The following is a description of a gene set: Intracellular signaling by second messengers species: Homo sapiens Human Gene Set: REACTOME_INTRACELLULAR_SIGNALING_BY_SECOND_MESSENGERS, and this is the list of marker genes: PRKACB (NCBI Gene Id 5567), PDE1B, PIK3R1, PTEN, PPP2R5C, FGF17, PHLPP1, ADCY7, EGF, MAPK1, RRAGD (NCBI Gene Id 58528), CHD4, PRKAR1A, PRKCD, PSMD6, CD28, JUN, FGF1, FGF2, TRAF6, HDAC5, EED, GRK2, NTF4, FGF5, RPS6KB2, FOXO4 (NCBI Gene Id 4303), PSMB1, MAPKAP1, PIK3AP1 (NCBI Gene Id 118788), HDAC7, TSC2, PLCG1, ATN1, CREB1, CAMK4, CBX8, HDAC1 (histone deacetylase 1), PSMD13, KLB, PRKAR2B, CBX6, PHC3, LAMTOR2 (late endosomal/lysosomal adaptor, MAPK and MTOR activator 2), PHC1, NEDD4, PDGFRB, PDGFA, PIP4K2A (NCBI Gene Id 5305), PDE1C, RRAGA, PRKAR1B, RICTOR, CDKN1B, PSMC2, ADCY1, UBB, PTPN11, PSMA5, KITLG (KIT ligand), UBC, LAMTOR1, EREG, PSMB6, LCK, CD19, UBA52, PDE1A, PPP2R5E, ICOS, VAV1 (NCBI Gene Id 7409), GAB2, ADCY9, PSMA7, HDAC2, PRKACG, PSMA1, FGF16, CSNK2A2, ADCY3, FGF3, CSNK2A1, PPP2CB, RHOG, PPP2CA, ERBB3, PIK3CG, RRAGC, GSK3A, IRS2, MDM2, AKT3, KIT (NCBI Gene Id 5086), MTA3, FGF10, GRB2, PIP4K2B, EGR1, SLC38A9, PML, FGF8, KPNA2, CDKN1A, FGF7, FOXO1, GATAD2A, SNAI1, IRS1, AKT2, ITPR3, MECOM, RRAGB, CAMK2B, EPGN, PSMA4, INS, FLT3LG, BTC, FGF19, CD86 (NCBI Gene Id 942), PSMB2, PSMD3, PSMD12, CHUK, GSK3B, TRIB3 (tribbles pseudokinase 3), USP7, SRC, RNF2, TGFA, TNKS (tankyrase), IRAK4, PSMC1, PSMC6, SUZ12, PSMC3, PIK3R5, SALL4, AKT1S1, IER3, PSMC5, NTRK3, NTF3, SCMH1, PIK3CB, AGO2, AREG, PSMD7, PSMB4, BAD, NTRK2, AHCYL1, FYN, CAMK2A, PRKACA, MAF1, STUB1, CAMKK1, ATF2, PHC2, REST, BDNF, CHD3 (chromodomain helicase DNA binding protein 3), PSMD2, TNKS2, IL1RL1, FGF23, NBEA, MOV10, PSMC4, PSMD8, TRAT1, MKRN1, PSMA6, EZH2, PDGFB, KL, NRG1, MBD3, FGF9, PSMB3, MET, MTOR, BMI1, IL33, NRG2, FOXO3, ITPR1, FGFR1 (fibroblast growth factor receptor 1, NCBI Gene Id 84151), RCOR1, PRKX, MAPK3, ERBB4, PIK3CD, MLST8, RPTOR, CASP9, PRKCG, FGF6, CAMK2G, PSMD1, PSMB5, HBEGF, PIK3R6, PSMB7, RBBP4, MTA1, CBX4, AGO3, GATAD2B, PIP4K2C, TNRC6C, PPP2R5B, SGK1, PIK3CA, ERBB2, IL1RAP, ITPR2, FGF22, RNF146 (ring finger protein 146), CAMKK2, ADCY8, PDPK1, FGFR3, OTUD3, GAB1, NRG4, WWP2, FGF18, ADCY5, NRG3, SEM1, FGF4, CAMK2D, PPP2R1A (protein phosphatase 2 scaffold subunit Aalpha), PSMD14, CALM1, ADCY6, SNAI2, FGFR2, ADRM1, RAC2, TRIM27, PSMA2, STRN, INSR, RHEB, PRR5, MTA2, FLT3, LAMTOR4, FRS2, TNRC6B, THEM4, HDAC3, LAMTOR5, PIK3R2, PPP2R5D, ESR1, PSMD11, PRKAR2A, TP53, NR2E1, PRKCE, KDM1A, TNRC6A, PPP2R1B, XIAP, PPARG, AGO4, ESR2, EGFR, PPP2R5A, NR4A1, PSMA3, FGFR4, MYD88, FGF20, CBX2, AGO1, CD80, PRKCA, RBBP7, PIP5K1C, PIP5K1B, USP13, FRK, PIP5K1A, RPS27A, IRAK1, AKT1, CSNK2B, ADCY4, PIK3R3, RAC1, PHLPP2, PDGFRA, PREX2, LAMTOR3, RING1, FOXO6, HGF, ADCY2